Given this list of marker genes Apoa1, Pon1, Lrp8, Gpihbp1, Cd36, Scarb1, Hspd1, Abca1, Apoa2, Trem2, Pltp, here is a description of the gene set: Mouse Gene Set: GOMF_HIGH_DENSITY_LIPOPROTEIN_PARTICLE_BINDING species: Mus musculus Binding to high-density lipoprotein particle, a lipoprotein particle with a high density (typically 1.063-1.21 g/ml) and a diameter of 5-10 nm that contains APOAs and may contain APOCs and APOE.